Given this list of marker genes SIX3, HESX1 (NCBI Gene Id 8820), POU1F1, GLI2, FOXA2, OTX2, PROP1, LHX4, GATA6, ROBO1, here is a description of the gene set: Absence of the anterior pituitary gland resulting from a developmental defect. Anterior pituitary agenesis studied in species Homo sapiens Human Gene Set: HP_ANTERIOR_PITUITARY_AGENESIS